The following is a description of a gene set: Comprehensive identification of all functional elements encoded in the human genome is a fundamental need in biomedical research. Here, we present a comparative analysis of the human, mouse, rat and dog genomes to create a systematic catalogue of common regulatory motifs in promoters and 3' untranslated regions (3' UTRs). The promoter analysis yields 174 candidate motifs, including most previously known transcription-factor binding sites and 105 new motifs. The 3'-UTR analysis yields 106 motifs likely to be involved in post-transcriptional regulation. Nearly one-half are associated with microRNAs (miRNAs), leading to the discovery of many new miRNA genes and their likely target genes. Our results suggest that previous estimates of the number of human miRNA genes were low, and that miRNAs regulate at least 20% of human genes. The overall results provide a systematic view of gene regulation in the human, which will be refined as additional mammalian genomes become available. species: Homo sapiens Human Gene Set: SCGGAAGY_ELK1_02 Genes having at least one occurrence of the highly conserved motif M3 SCGGAAGY in the regions spanning 4 kb centered on their transcription starting sites. This matches the ELK1 transcription factor binding site V$ELK1_02 (v7.4 TRANSFAC). from publication Xie X, Lu J, Kulbokas EJ, Golub TR, Mootha V, Lindblad-Toh K, Lander ES, Kellis M (PMID 15735639), and this is the list of marker genes: SUPT16H, SCFD1, TBC1D13, SFSWAP, SHQ1, WTAP, GTF2A1, ATAD1, RWDD2A, MFN1, SPTY2D1, ZBTB43, CES2, LSR, WDR74, SEC11A, PRAC1, GK, CCDC28A, POLR3D, SF3B1, ZPR1, CREBZF, SNTB2, RNF121, POU4F2, VMP1, WNT1, ZKSCAN5, SNF8, MTPN, TOMM70, RBBP4, KRIT1, ZNF112, RPL36AL, ACAD11, TTF1, IQCK, MAPK8IP3, SIRT2, ELK3, PDLIM1, COPE, RPS6KA3, PRPF19, UNC50, CSNK2B, CSTF3, YRDC, KAT5, POLR1C, CDC45, CDC37, CPSF3, CNPY3, SPICE1, TMEM101, STOML2, AGPAT2 (NCBI Gene Id 681), CARS1, NIF3L1, SRSF9, CEP95, NECAP2, IRF2, ANKS3, POLR3H, COX6B1, RING1 (ring finger protein 1), COG3, LEPROT, ZCCHC7, DCDC1, KDM6A, SCO1, PTPN1 (NCBI Gene Id 5770), SRSF4, INO80E, PSMC1, NAGK, PSMA6, EFL1, COX6A1, FMR1, MARK3, EXOC5, ING2, SLC12A2 (NCBI Gene Id 6558), STRN, PPIL2, MRPS10, TNK2, PIGW, MRPS21, STX12, AP5M1, AFG2A, ZNF322, RAB2A, GAPDH, PRKAG2, EAPP, APEH, ANAPC4, C12orf57, DNAJC14, VCPIP1, RPL27, DLX4, ABCD4, SLC7A10, SNRNP27, PDZD11, SH3GLB2, INIP, COX17, AP1B1, MPZL3, ROM1, TMCO1, PDCD6, EEFSEC, WDR93, REXO5, HMG20A (high mobility group 20A), EML3, OTUB1, ASB8, AURKA, PANK3, AP1S2, INSIG2, TBCE, FBXO38, BCDIN3D, CLN3, UBE2F, DNMT1, SEMA4A, MED14, PHF23, TSTD2, PDE12 (NCBI Gene Id 201626), TMX1, YTHDF3, VTA1, DNAI1, TM9SF1, PCGF1, EVC2, ZNF384, YIPF3, TIMM10, HPS1, LZTFL1, PMM2, MFSD9, LRRC28, SEPTIN7 (septin 7), PCBP1, C6orf47, SETDB1, RAP2C, C2orf42, YIPF5, MCM8, WDR46, SNIP1, PABPC4 (poly(A) binding protein cytoplasmic 4), PPP1R11, ZNF653, PSMB1, SRD5A1, CLDN5, EIF2B2, POLA1, FDXR, MTFR1L, GTF3C2, CYB561A3, ZER1, SPSB2, KLHDC3, ENTPD8, CFAP298, ACO2, TGDS, COPS7A, TUBGCP4, MAGED2, PSME3, SPG21, DNAAF2, KANSL3, CD2BP2, TRO, CSTF1, LYPLA2, ZBTB41, ARID4A, DDX1, HERC4, AAGAB, NDUFS1, GRWD1 (glutamate rich WD repeat containing 1), STAG1, TMEM68, GPR155, CALU, MTNAP1, OPN1LW, KMT5A, DIAPH1, MRPS18A, BRME1, GSPT1, BLZF1, UXT, NF1, LSM5, ZNF79, SIPA1, MASTL, RRP36, TAX1BP1, LRATD2, PRKAB1, TFB2M (NCBI Gene Id 64216), TAOK2, EN1, RPS25, CCDC103, DNAJC1, MARK2, TENT5A, YKT6, TMEM167A, SRSF6, SLC39A9, MKRN1, CLCN2, EFTUD2, CNTROB, CRB3, BANF1 (barrier to autointegration nuclear assembly factor 1), DCTN5, DDX55, EXTL2, UBA1, SAR1A, PGS1, POLR2K, USF1, PARPBP, RNF168, RPL19 (NCBI Gene Id 6143), NUDT5, SEPTIN10, RAB5A, KCTD5, DDX39B, CIAO2B, GSE1, RCSD1, NMT1, ANKMY2, C1QBP, TMEM127, PPP1R35, LIMD2, UVRAG, COPS7B, SZT2, PHLDB3, PER1, ABCA1, TRADD, SYT5, PARP11, PCBP2, GJB1, TFAP2C, SIRT3, TBP, ITPA, CIP2A, INO80B, ARHGEF7, BZW2, PYM1, TIE1 (NCBI Gene Id 7075), BRCC3, ACYP1, CELF1, EXOC3L1, TMEM199, DNTTIP1, URM1, C9orf40, SF3B4, FAM200A, RNF41, ZBTB9, CCDC25, NFS1, ALAD, GPATCH2, SDHAF2, BECN1, HIRIP3, SIRT6, SHANK2, NR1H2, TOMM20, CHUK, SUMO1, SART1, MCTS1, TBC1D22A, CHID1, PHTF1 (putative homeodomain transcription factor 1), SLC35F6, ZNF410, ANAPC15, BABAM1, RFESD, PDAP1, TAF11, TPX2, GGA1, MAPKAPK2, CBX8, SLC35B3, IRX3, KLHL35, MLYCD, BACE1, CPEB4, RSPRY1, KDM5A, PRDX5, RAB5C, RPL32, EDC4, CYB561D2, USP3, LRRC49 (leucine rich repeat containing 49), MRPL3, UQCRH, MTMR4, UBE2Z, TIGD4, RHOQ, METTL6, HCCS (NCBI Gene Id 4307), STX6, TENT2, PTHLH, MED15, OVCA2, B3GALT4, CNOT3, C2orf49, ZC3H13, CXCR5, TMEM208, EMG1, EGR1, ZNF23, UFC1, CLEC18C, ARF3, ZSCAN20, ZDHHC5, FAM174A, MYO19, METTL5, C1orf122, TRMT112, FCF1, ZNF646, PSMB7, AKT1S1, MMUT, TYMP, NIFK (nucleolar protein interacting with the FHA domain of MKI67), PSMD12, ASB1, CCDC171, CLMN, WDR83OS, VCF1, SRP19, EIF3M, PLP2, PRKAG1, ACP2, CENPQ, UBR4, ASB6, FRS2, NARS1, GTF3C1, SUGT1, CLDN7, GNL3L, CPT2, SEC24C, DAGLA, TRIM39, SLC9A8, TIGD6, CAAP1, GFI1, TCF7, YEATS2, EME1, WASF2, SLC25A1, PUF60, MINDY1, CCDC174, SHKBP1, DDX49, ATP5F1A, RTF2, ZSCAN25, KNCN, UGGT1, PRPF18, ZNF394, APTX, RBBP5, ARFIP2, LEPR (NCBI Gene Id 3953), MTMR9, NOP53, LYRM1, SPRED2, CCDC47, POLR2M, TIMMDC1, RPL6, MAP3K11, DHX57 (NCBI Gene Id 90957), MYG1, SMARCAD1, USP16, YTHDF2, DDX50, PEX2, PCDH11X, INTS3, TTC23, FAM219A, CXXC1 (CXXC finger protein 1), ERCC6, DPP3, YME1L1, JAG1, WAS, INO80, POLDIP2, CETN3, SF3A1, ESCO1, SUPT6H, MCMBP, PYROXD1, EPN1, TNRC6A, PHC3, NCBP1, DDX5, LTN1, NSUN2, IPPK, EMC4, VEGFB, DNAJC24, POMP, SLC25A14, HIRA, YJU2B, TNPO3, NOSIP, PKN3 (protein kinase N3), NDUFAF3, MAP3K6, ACVR2A, SLC35A5, ARFIP1, ROMO1, NMNAT1 (nicotinamide nucleotide adenylyltransferase 1), DLST, CPSF7, RAD51D, LSM4, FANCD2, ADAMTSL5, NUTF2, DDX47, RPS18, LAS1L, ACIN1, LRRC41, POLR2F, DPCD, HPS3, SMUG1 (single-strand-selective monofunctional uracil-DNA glycosylase 1), NUP107, GNAI3, CHRNA1, HNRNPD, ENTHD1, ENOX2, PIGO, SLC35C2, DNAJC7, GRIPAP1, SNX1, SAMD10, TRIM46, TPGS1, SNX12, NOL12, MEIS2, DHX30, MEA1, TPI1P2, EFNA5, GOLGA3, RNGTT, PTRH2, ZNF35, LOXL4, MAP1B, VAC14, LRP10, COG4, COMMD5, DNAJA1, RNF185, PPME1, MGAT2, GEN1, DCAKD, ACTR2, DNAI4, THAP10, RPS6KC1, GMPR2 (NCBI Gene Id 51292), ZZEF1, PPIL1, TMEM230, BAG6, ATP8B4, PSME3IP1, VPS18, MTX2, NOC2L, ING4, PCYT1A, PGM3, NKIRAS2, SF1, COX15, EIF5A, CDC123, RHOA (ras homolog family member A), THUMPD3, UBL5, TMBIM4, TCOF1, NUDT6, ZNF580, MRPL40, UBA5, MRPL49, ITGB1BP1, STEEP1, ATP5ME, DGUOK, KRR1, CSAD, ODF2, NUDT21, CNST, MIEN1, ADNP, SMC6, SUSD1, GNL2, DHX15, XPO5, TMEM186, ZCCHC9, HARS2, ATXN10, TMUB1, SLC39A7 (solute carrier family 39 member 7), SLC38A10, EIF4A1, STX4, DHX36, XAB2, FBXO22 (F-box protein 22), RPL37, UFD1, VRK3, SPATA17, TTPAL, WARS1, EIF2AK1, GART, CTPS2, ALDOA, TDRD3, ATP6V1H, RABGEF1, CCP110, BAD, NAA20, MEF2B, CAP1, TCTA, GABARAPL2, HYPK, C18orf21, SON, KAT7, MTF1, GTF2A2, MAPKAP1, HARS1, TSPAN31, POGZ, EHD4, WFDC3, KRTCAP2, COX8A, GDE1, RB1CC1, POLR2H, GPN2, ZNF180, NUDT22, NECAP1, WRAP53, MYL6B, PIH1D2, AP3B1, ZNF513, C19orf47, PSMC2, TLK1, ZKSCAN7, SRPRA, CENPO, METAP2, MAPRE1, RXRB, DIABLO, RBM22, HNRNPLL, HIKESHI, TTC14, PEX11A, CSNK1E, SRBD1, RPS6, RPL26, MORC3, ERI1, CDCA3 (NCBI Gene Id 83461), CHERP, RSU1, DHX8, HSP90B1, SSBP1, UGGT2, KTI12, RABGGTA, C22orf23, ZBTB11, TADA3, VPS52 (NCBI Gene Id 6293), AREL1, SSU72, DDX42, ZNF22, LLPH, LTV1, TRAPPC10, PUS1, ODAD4, PMPCB, MTA2, MAP4K2, COMMD6, EIF1AD (NCBI Gene Id 84285), CLASRP, SKP2, SPAG8, PALB2, WDR35, HSPA4, BIN3, YIPF1, SIDT1, STPG2, RNF181, BMP2K, RPL11, ZNF655, TXNDC12, FBXO33, NKAPD1, NMNAT2, MRPL33, MTMR14, FBXL8, ZNF800, PTPN23, RPS19BP1, FANCF, USP5, NTHL1, TPM3, FBXO36, AMZ2, ZNF585A, ZKSCAN8, CNOT10, NPRL2, FUZ, GON4L, WEE2-AS1, HSP90AB1 (heat shock protein 90 alpha family class B member 1), RAVER1, SDR42E1, ERI2, SLC30A7, ZSWIM8, SCAMP2, PROSER1, RRS1, TBCC, CUTC, KIF4A, MTAP, KDM4D, PPIL3, PTPN2, PPAN, ITM2C, TRAPPC4, RPS3A, SLIRP (NCBI Gene Id 81892), TMEM33, CHPF, ERCC3, MOCS3, FNDC8 (fibronectin type III domain containing 8), TRAF7, CCND2, DPP8, AP1M1, LEF1, IFI30, GLE1, ATP1B2, AP2S1, ZNF48, TMEM222, PRKACB, HBP1, ADPRM (NCBI Gene Id 56985), CLASP1, BTBD1, PLK4 (NCBI Gene Id 27119), KLHL18, ANKS1A, C6orf89, R3HDM1, UTP3, ZFP3, DNAJB1, DAB2IP, SLC25A17, ENDOV, PITPNA, TMEM62, TRMT10A, IER2, HNRNPH1, ZRANB2, PLA2G6, RALGAPB, GMIP, CEP41, ELP2, COPS3 (COP9 signalosome subunit 3), FBXL9P, EIF2S1, MAP4K3, WRAP73, ZBTB8OS, RPAP1, ATP2A2, USP32, ZFYVE27, SND1, WFDC2, EXOSC3, ARPC4, FBXO3, TNKS2, SLC31A1, MDM4, AOPEP, CCDC85B, CEP164, TEFM, PSMA4, MLEC, BCKDHA, DNAJB5, TMEM59, TBC1D17, ACBD5, MCRS1, PPIG, LASP1, CCZ1B, MTERF1, LYL1, KCTD13, DHX40, RNMT, GPANK1, CCNDBP1, PER2, TBX6, COX5B, SF3A3, TRMT1, FAM120AOS, ZNF408, SCFD2, ZNF512, BNIP2, STAG2, DNAAF8 (NCBI Gene Id 146562), HERPUD2, ZNF585B, PHF20L1, ZNF184, PICK1, CIAO1, FUT8, TP53, AATF, CUL7, GFUS, TRAPPC1, WDR55, ERH, PPP4C, USB1, SLC52A2, RNF2, NUDT12, CFAP36, FBXW9, COG7, LINC01138, MINDY2, AIP, PIGC, RPLP2, SMAP2, CYB5D2, MAD2L1BP, HSPH1, MINDY3, BLM, TRIM41, FASTKD5, VPS26C, WDR48, PEX16, PFDN6, MOSPD3, CORO1C, TMEM187, NOL7, TWNK, PPHLN1, ARFGAP1, SRP54, EBNA1BP2, RMND5B, CGGBP1, RBM45, CCDC71, E2F4, CBLL1, SUGP1, SEC31A (SEC31 homolog A, COPII coat complex component), NRAS, NEDD8, SEPTIN9, NASP, EP300, EDEM3, PABPC1, SLC25A4, BCL2L1, ATR, UFM1 (ubiquitin fold modifier 1), MPDU1, SIGIRR, YWHAE, STARD3 (StAR related lipid transfer domain containing 3), UBLCP1, ITFG1, GALNT10, GRPEL2, FBXO8, KXD1, PRPF6, YARS1, TRPT1, SLC25A20, ZCRB1, ZNF70, ANKHD1-EIF4EBP3, SLC39A6, DPH2, MCL1, LIMD1, TOMM40, FAM120A, RPS5, RFC4, FAM210A, MSANTD2, RAB4B, PAIP2, NIPBL, CTTNBP2NL (CTTNBP2 N-terminal like), MTIF2, SHLD1, ZFYVE16, CEP44, NXT2, PIP4K2A, TAF1B, PARS2, LIN28A, GAR1, GCC2, RPE, CCNT1, ARPC2, MRPL43, EDRF1, RAB8A, IPO4, DCLRE1C, UBE2E3, ARHGAP1, PIGT, ZFAND3, MTCP1, ELK4, B3GAT3, ATP6V1D, UNC13D, RBM19, KDM3B, HSPB2, ATP2C1, SRP14, RBCK1, RRP15, F11R, KATNB1 (NCBI Gene Id 10300, katanin regulatory subunit B1), ZFP64, RNPS1, SERTAD1, SLC25A38, THG1L, C3orf38, STIM1, B3GALT6, NFKBIB, IL17RA, R3HCC1L, WASHC4, C14orf119, CBL, MCM7, UBA2, PPP2R3C, ATM, CDX2, CSTF2T, ATP13A1, TIMM10B, ZBTB3, MRM1, AP4M1, YWHAB, JADE1, BTAF1, DCP1A, TMEM191A, XRCC4, ZNHIT2, IQCH, MRPL27, RPS3, POLH, STK4 (serine/threonine kinase 4), KIAA0825, CWC15, SUPT5H, POLL, TBC1D5, UBR1, FKBPL, PHB2, TRMT6, EXOSC5, PDE5A, NUP155, RAB11B, ZNF687, HAT1, LDAH, ARMC7, PHKB, CYB5R4, AAK1, SDF2, SYNJ1, RAD23A, EML2, ATP7A, FOXH1, EEF1B2, PSMD13, BCAT2, SLC25A5, HDAC10, NME7, PCED1A, ZNF24, USPL1, TTI2, KCNT2, ELAVL2, NUDC, U2AF2, RAB7A, ACTB, MED30, UBE4A, ACTR6, SYNRG, PCDH11Y (protocadherin 11 Y-linked), LMAN2, CTSK, GGT7, SOWAHC, NAA60, RFXANK, TRIM11, NRDC, UHMK1, PITX2, TFCP2, ARL5B, KYAT1, MON1B, STX10, GTSF1, ZSCAN29, SEC61A1, TIMM23 (translocase of inner mitochondrial membrane 23), HIF1AN, DPM1, PSMA5, CWC25, DYNLT2, TCEANC2, PAFAH1B2, RPS14, OGG1, AKTIP, TAF5L, CEP55, ATG5, RPL37A, PRADC1 (protease associated domain containing 1), CLINT1, RPL31, AKAP10, EVX1, CSGALNACT2, WDR83, RNF13, PDLIM5, RNF20, PGAM5, SPINDOC, CFL1P1, MRPL52, DDHD1 (DDHD domain containing 1), ZNF668, TUFM, CTNNBL1, SF3B3, C1orf210, ZSCAN12, UBXN1, SNRPB, DDOST, RPS27L, MEIS1, CHORDC1, WDR1, PPP1R21, DBR1, PHF5A, UBE2N, EIF3H, TIPRL, PARL, ZNF22-AS1, BRWD3, NPAT, CDK13, KDF1, MED8, ID3, RPF1, TMEM138, CMTR2, MLLT6, EGR2, BUD31, LRRFIP2, DHX37, NUP37, SAP130, RAB24 (RAB24, member RAS oncogene family), THAP11 (NCBI Gene Id 96844), ERCC1, FIBP, JAGN1, AGL, CARF, VPS53, DDIT3, SEC13, TAF10, PRRC2C, PRELID1, PSMC4, DR1, LZIC, DCAF1, EAF1, GSKIP (NCBI Gene Id 51527), GOSR2 (golgi SNAP receptor complex member 2), SLC36A1, COQ8B, LINC03124, EMC3, KIF9, VPS16, AZI2, SEMA3F, RBBP6, JPH4, CCT7, RRAS, CTR9, USE1, GPATCH2L, MFSD5, SMU1, KICS2, INVS, PARP8, TRMO, SHC1, C15orf39, ANKRD17, TSC2, CHMP2A, TOMM22, MTMR2, DCUN1D3, CFAP57, ANKHD1, VPS13B, FBXL6, WDR73, KLHL17 (NCBI Gene Id 339451), SEC23IP, LEPROTL1, ALKBH1, MORN2, DYNC2I2, AK4, ATG16L1, GRB2, TGS1, PURB, DZIP3 (NCBI Gene Id 9666), NEDD1, SNRPE, GIT2, RFC2, JOSD2, ATF6B, STK40, ULK4, TRMT10B, MIER1, FOXRED1, DCAF10, PEX6, CKS1B, UBE2V2, EIF3L, STXBP2